The following is a description of a gene set: studied in species Mus musculus Mouse Gene Set: GOBP_AGGREPHAGY The selective degradation of protein aggregates by macroautophagy., and this is the list of marker genes: Atg4c, Atg4b, Htt, Atg5, Kat5, Zdhhc19 (NCBI Gene Id 385631), Ubqln1, Csnk2a1, Wdr81, Atg4a-ps, Atg4d, Bag3, Lypla1, Atg4a, Wdfy3, Hdac6, Hspb8, Sqstm1